The following is a description of a gene set: studied in species Mus musculus Mouse Gene Set: GOMF_UBIQUITIN_LIGASE_COMPLEX_SCAFFOLD_ACTIVITY The binding activity of a molecule that brings together an ubiquitin ligase and an ubiquitin ligase-substrate adaptor, permitting those molecules to function in a coordinated way., and this is the list of marker genes: Cul7, Cul5, Skp1, Ddb1, Cul4a, Cul1, Cul3, Cul2